Given this list of marker genes LIMK1, MLX, MEFV, NCF1, VCL, ALPK3, BUD23, GTF2IRD1, GJA5, IL10, IL23R, IFNGR1, IL12A-AS1, STAT4, IDUA, ABCC6, TAFAZZIN, PTPN11, KLRC4, STX1A, VPS37D, PDGFRA, CLIP2, METTL27, GBA1, CSRP3, ERAP1, HLA-B, C4A, DNAJC30, TLR4, TMEM270, MYH7, TRAF3IP2, SP110, CLEC7A, GTF2IRD2, ENPP1, PRKAR1A, IL17RA, IL17RC, RFC2, MCM10, SLC22A5, LDB3, BRAF, GTF2I, MYL3, EIF4H, FKBP6, IL12A, ELN (elastin), ADA2, RAF1, UBAC2, BAZ1B, GLA, ACTN2, IL12B, IL17F, CCR1, TBL2 (NCBI Gene Id 27203), FAS, here is a description of the gene set: species: Homo sapiens Human Gene Set: HP_ABNORMAL_ENDOCARDIUM_MORPHOLOGY An abnormality of the endocardium. Abnormal endocardium morphology